The following is a description of a gene set: A sperm-specific voltage-gated calcium channel that controls the intracellular calcium ion concentration and, thereby, the swimming behavior of sperm. Consists of a heteromeric tetramer surrounding a calcium ion- selective pore. May also contain additional auxiliary subunits. Mouse Gene Set: GOCC_CATSPER_COMPLEX studied in species Mus musculus, and this is the list of marker genes: Catspere2, Tmem249, C2cd6, Catsper2, Catspere1, Catsperg2, Catsper4, Hspa2, Catsper3, Catsperb, Efcab9, Catsperg1, Slco6c1, Catsperd, Catsperz (cation channel sperm associated auxiliary subunit zeta), Tmem262, Catsper1